The following is a description of a gene set: from publication Cairo S, Armengol C, De Reyniès A, Wei Y, Thomas E, Renard CA, Goga A, Balakrishnan A, Semeraro M, Gresh L, Pontoglio M, Strick-Marchand H, Levillayer F, Nouet Y, Rickman D, Gauthier F, Branchereau S, Brugières L, Laithier V, Bouvier R, Boman F, Basso G, Michiels JF, Hofman P, Arbez-Gindre F, Jouan H, Rousselet-Chapeau MC, Berrebi D, Marcellin L, Plenat F, Zachar D, Joubert M, Selves J, Pasquier D, Bioulac-Sage P, Grotzer M, Childs M, Fabre M, Buendia MA (PMID 19061838) Human Gene Set: CAIRO_HEPATOBLASTOMA_POOR_SURVIVAL species: Homo sapiens Genes whose expression classifies hepatoblastoma tumors as belonging to either rC1 or rC2 subtypes and whose expression predicts poor survival. Hepatoblastoma, the most common pediatric liver cancer, is tightly linked to excessive Wnt/beta-catenin signaling. Here, we used microarray analysis to identify two tumor subclasses resembling distinct phases of liver development and a discriminating 16-gene signature. beta-catenin activated different transcriptional programs in the two tumor types, with distinctive expression of hepatic stem/progenitor markers in immature tumors. This highly proliferating subclass was typified by gains of chromosomes 8q and 2p and upregulated Myc signaling. Myc-induced hepatoblastoma-like tumors in mice strikingly resembled the human immature subtype, and Myc downregulation in hepatoblastoma cells impaired tumorigenesis in vivo. Remarkably, the 16-gene signature discriminated invasive and metastatic hepatoblastomas and predicted prognosis with high accuracy., and this is the list of marker genes: C1S, CYP2E1, RPL10A, DLGAP5, ALDH2, NLE1, BUB1, E2F5, GHR, APCS, AQP9, IGSF1, DUSP9, APOC4, AFP (alpha fetoprotein), HPD